Given this list of marker genes ADORA1, HTR2A, HCN1, PRKN, NPY2R, DRD2, ATAD1, DRD3, GRIK2, GRIK3, here is a description of the gene set: Any process that stops, prevents, or reduces the frequency, rate or extent of glutamatergic synaptic transmission, the process of communication from a neuron to another neuron across a synapse using the neurotransmitter glutamate. Human Gene Set: GOBP_NEGATIVE_REGULATION_OF_SYNAPTIC_TRANSMISSION_GLUTAMATERGIC studied in species Homo sapiens